Given this list of marker genes SYTL4, NLGN1, NLGN2, SYTL5, NLGN4Y, CASK, NLGN4X, LRRTM2, SYTL1, SYTL2, NLGN3, CLSTN3, CPE, SYTL3, here is a description of the gene set: species: Homo sapiens Human Gene Set: GOMF_NEUREXIN_FAMILY_PROTEIN_BINDING Binding to a neurexin, a synaptic cell surface protein related to latrotoxin receptor, laminin and agrin. Neurexins act as cell recognition molecules at nerve terminals.